Given this list of marker genes CLEC4D, MUC21, MUC16, FYN, CLEC4C, MUC13, CLEC4E, FCER1G, MUC6, CLEC4A, MUC15, MUC12, MUC19, MUC7, MUC3B, MUC17, PLCG2, MUC20, MUCL1, LYN, MUC3A (NCBI Gene Id 732156), env, CLEC6A, MUC2, CLEC10A, MUC4, MUC5B, SYK, MUC1, MUC5AC, here is a description of the gene set: species: Homo sapiens part of: C-type lectin receptors (CLRs) Dendritic cell-associated C-type lectin-2 (Dectin-2) family of C-type lectin receptors (CLRs) includes Dectin-2 (CLEC6A), blood dendritic antigen 2 (BDCA2/CLEC4C), macrophage C-type lectin (MCL/CLEC4D), Dendritic cell immunoreceptor (DCIR/CLEC4A) and macrophage inducible C-type lectin (Mincle/CLEC4E). These receptors possesses a single extracellular conserved C-type lectin domain (CTLD) with a short cytoplasmic tail that induces intracellular signalling indirectly by binding with the FCERG (High affinity immunoglobulin epsilon receptor subunit gamma) except for DCIR that has a longer cytoplasmic tail with an integral inhibitory signalling motif (Graham & Brown. 2009, Kerschera et al. 2013). CLEC6A (Dectin-2) binds to high mannose containing pathogen-associated molecular patterns (PAMPs) expressed by fungal hyphae, and CLEC4E (mincle) binds to alpha-mannaosyl PAMPs on fungal, mycobacterial and necrotic cell ligands. Both signaling pathways lead to Toll-like receptor (TLR)-independent production of cytokines such as tumor necrosis factor (TNF) and interleukin 6 (IL6). Similarities with Dectin-1 (CLC7A) signaling pathway suggests that both these CLRs couple SYK activation to NF-kB activation using a complex involving CARD9, BCL10 and MALT1 (Geijtenbeek & Gringhuis 2009). Reactome Pathway: Dectin-2 family